Given this list of marker genes H3-3A, H3C1, H2AC14, H2AX, H2BC12, H2BC5, H2BC13, H2BC1, H2AC18, H2BC17 (NCBI Gene Id 8348), H2AJ, H4C1, H3C15, H2BC15, MAPK3, H2AC6, UBTF, H2AZ2, H2AC20, H2BC14, H2BC11, H2BC21, H2AB1, H2BC3, H2BC12L, H2BC26, H2AC7, MBD2, H2BC9, H2BC4, H2AC4, here is a description of the gene set: species: Homo sapiens part of: RNA Polymerase I Promoter Clearance Reactome Pathway: RNA Polymerase I Promoter Opening The activity of the upstream binding factor (UBF-1) plays an important role in the regulation of rRNA synthesis. Studies reveal that phosphorylation of UBF-1 is required for its interaction with the RNA polymerase I complex, suggesting that phosphorylation of UBF-1 bound to the rDNA promoter during promoter opening modulates the assembly of the transcription initiation complex.